Given this list of marker genes SLC25A44, SLC3A2, SLC43A1, SLC6A14 (solute carrier family 6 member 14), SLC43A2, SLC38A9, SLC7A8, SLC6A20, SLC7A5 (solute carrier family 7 member 5), SLC6A15, here is a description of the gene set: studied in species Homo sapiens Enables the transfer of branched-chain amino acids from one side of a membrane to the other. Branched-chain amino acids are amino acids with a branched carbon skeleton without rings. Human Gene Set: GOMF_BRANCHED_CHAIN_AMINO_ACID_TRANSMEMBRANE_TRANSPORTER_ACTIVITY